The following is a description of a gene set: Human Gene Set: GOBP_GLOMERULUS_VASCULATURE_MORPHOGENESIS The process in which the anatomical structures of the glomerulus vasculature are generated and organized. The glomerulus vasculature is composed of the tubule structures that carry blood or lymph in the glomerulus. studied in species Homo sapiens, and this is the list of marker genes: NOTCH2, PDGFRB, PDGFRA, NOTCH3, TCF21, BMP4